The following is a description of a gene set: studied in species Homo sapiens Human Gene Set: GOBP_REGULATION_OF_MAST_CELL_DEGRANULATION Any process that modulates the frequency, rate, or extent of mast cell degranulation., and this is the list of marker genes: IL13, PLA2G3, SPHK2, FERRY3 (FERRY endosomal RAB5 effector complex subunit 3), VAMP8, IL4R, UNC13D, STXBP2, LYN, SYK, STXBP1, FOXF1, GAB2, PDPK1, CD84, FCER1G, ADORA2B (NCBI Gene Id 136), RAC2 (Rac family small GTPase 2), GATA2, FES, IL13RA2, FGR, VAMP7, RABGEF1, GATA1, SNX4, LGALS9, ADGRE2, CD300A (NCBI Gene Id 11314)